The following is a description of a gene set: Human Gene Set: GOMF_N_ACETYLGLUCOSAMINE_6_O_SULFOTRANSFERASE_ACTIVITY studied in species Homo sapiens Catalysis of the reaction: 3'-phosphoadenosine 5'-phosphosulfate + N-acetyl-D-glucosamine = adenosine 3',5'-bisphosphate + N-acetyl-D-glucosamine 6-sulfate., and this is the list of marker genes: CHST3, CHST7, CHST5, CHST6, CHST4, CHST1, CHST2